Given this list of marker genes Synj1, Rab3gap1, Bcl2l1, Syn1, Bloc1s3, Syndig1, Bloc1s1, Kifc2, Snca, Rab3a, Pten, Ap3s2, Dnm3, Tmem230, Pclo, Dnm1, Ap3m1, Kif5b, Arf1, Borcs5, Ap3s1, Bloc1s5, Pdzd11, Ap3d1, Bsn, Mx2, Btbd8, Syn3, Ap3m2, Snap91, Pcdh17, Ap1s2, Nlgn3, Lrrk2, Trim46, Syn2, Dtnbp1, Mylk2, Nlgn2, Nlgn1, Dnm2, Kif5a, Tor1a, Kif1a, Lin7a, Slc2a4, Snapin, Kif1b, Picalm, Cdk5, Bloc1s6, Ap3b1, Spg11, Bloc1s2, Fgfr2, Bloc1s4, Cdh2, Lin7c, Dpysl2, Syt4, Ctbp1, Lin7b, Cnih2, Madd, Map2, Ctnnb1, Nrxn1, Kif5c, Ap3b2, Magi2, here is a description of the gene set: studied in species Mus musculus Any process in which a synaptic vesicle or vesicles are transported to, and/or maintained in, a specific location. Mouse Gene Set: GOBP_SYNAPTIC_VESICLE_LOCALIZATION